The following is a description of a gene set: Abnormal bleeding of the umbilical stump following separation of the cord at approximately 7-10 days after birth. Human Gene Set: HP_ABNORMAL_UMBILICAL_STUMP_BLEEDING Abnormal umbilical stump bleeding species: Homo sapiens, and this is the list of marker genes: F10, SERPINF2, F13A1, F2, F13B, FGG, FGA, FGB